Given this list of marker genes ACTG2, PEX26, MKS1, PEX6, B3GLCT, TMEM216, PEX16, B9D2, PEX10, OFD1, ARL3, KDM6A, TBX4, CC2D2A, PEX2, LHX1, LAMC2, TCTN1, SALL1, SMC3, SH2B1, PEX1, MCTP2, FLI1, PORCN, NXN, TMEM107, TAF6, AMER1, LMOD1, SIX1, HNF1B, RAD21, GNA11, PEX3, SMC1A, SPOP, RPGRIP1, CEP290, PIGN, BBS2, LIG1, GPC4, INPP5E, TMEM237, TFAP2A, FIBP, TCTN3, PEX12, ROR2, LAMB3, TXNDC15, ARL6IP6, EYA1, BRD4, BUB1B, PEX5, BUB3, PEX11B, CEP57, PAX2, MBTPS2, RSPO2, HOXD13, NPHP3, PEX14, MYH11, SCAF4, KAT6B, TMEM231 (transmembrane protein 231), GREB1L, TMEM67, KMT2D, HDAC8, LAMA3, SNRPB, DLG5, SF3B2, ZEB2, GPC3, NIPBL, TCTN2, PIEZO2, PEX19, NRIP1, B9D1, PEX13, DHCR7, HDAC4 (histone deacetylase 4), RPGRIP1L, CHRM3, MYLK, WNT3, CSPP1, B4GAT1, SIX5, TRIP13 (NCBI Gene Id 9319), BUB1, MKKS, CD96, here is a description of the gene set: Human Gene Set: HP_MULTICYSTIC_KIDNEY_DYSPLASIA studied in species Homo sapiens Multicystic kidney dysplasia Multicystic dysplasia of the kidney is characterized by multiple cysts of varying size in the kidney and the absence of a normal pelvicaliceal system. The condition is associated with ureteral or ureteropelvic atresia, and the affected kidney is nonfunctional.